The following is a description of a gene set: Human Gene Set: HP_GOUT Recurrent attacks of acute inflammatory arthritis of a joint or set of joints caused by elevated levels of uric acid in the blood which crystallize and are deposited in joints, tendons, and surrounding tissues. Gout species: Homo sapiens, and this is the list of marker genes: SLC4A1, ANK1, HNF1B, PRPS1, SLC12A3, SPTA1, SLC37A4, APOE, PFKM, SEC61A1, MUC1, SPTB, G6PC1, LRP6, DNAJB11, EPB42, ADRA2A, CLCNKB, HPRT1, UMOD